Given this list of marker genes FBXO28, CTRC, TIMP1, GCLM, SYT17, MORF4L2 (NCBI Gene Id 9643), MAD1L1, ADRB2, RC3H2, RNF208, H2BC4, H2BC9, SPTBN1, ITGB6, TTC4 (NCBI Gene Id 7268), ADNP2, ZNF646, SOCS3, STAU1, GPC1, PELI1, B3GNT3, ATP2B1, GOLGA7, PDE4DIP, PCK1, ODF2, CAMSAP2, ALG13, TAF4, CA1, EIF6, EPHB6, BEX1, DENND1C, CAPN2, NFE2L2, ITPRID2, MUC5AC, HSPA13, TENT5A (terminal nucleotidyltransferase 5A), CEP70, HGS, SLC12A8, PTP4A1 (protein tyrosine phosphatase 4A1), SCARB2, MEX3C (mex-3 RNA binding family member C), IGBP1, TNFSF14, TMEM41B, HS3ST3A1, TENT4A, PPIF, PCGF3, LRRC8B, GAK, MYH7B (myosin heavy chain 7B), SCG2, CYTH4 (NCBI Gene Id 29776), CHSY1, PORCN, MAMLD1, MTSS2 (NCBI Gene Id 92154), SGMS1, PMAIP1, CNTRL, BACH2, S100P, AGAP2, GPR52, GVINP1, TSPYL1, HMGCS1, NRDC, SAMD9, ZBTB43, ZYX, ACYP1, PHF2, FASTKD5, SCG5, ERCC1, SRSF5, ENDOD1, ACSL3, GSPT2, SLC19A1 (NCBI Gene Id 6573), MOAP1, UBE2H, RGS1, CEBPB, AFF4, SFPQ, CNIH4, DOCK10, ECD, ELK4, NUP88, SFMBT1, LPXN, SMAD3, USP6NL, NR3C1 (nuclear receptor subfamily 3 group C member 1), CHGA, CHRD, MEF2D, GRM1, ANXA1, RNF19B, BCL2A1, CMKLR1, GLS, TMEM39A, ZNF426, ODR4, EIF4E, PRNP, ARHGEF7, PROC, SQLE, FFAR3, SUPT6H (SPT6 homolog, histone chaperone and transcription elongation factor), UBAP1, EFHD2, CMC2, HSPA9, RNF10, ANXA10, ATXN3, TM4SF1, DAPK2, C11orf24, DR1, ACTL8, ATF1, UBE3A, JMJD6, OSGIN1, LIPG, KCNC4, ZNF274, FAM83E, CALCOCO1, MMP2, NR4A1, DCP1A, CASP7, PSEN1, LEMD3, RHBDF2, ME1, ATF5, BCL10, AMMECR1, KPNA2, TNF, KRT8P12, ASH1L, MACO1, EPHB4, CLIP2, YES1, HGSNAT, ARF6, TGM1, DNAJB12, MDM4, UBA6, CBX4, NUP58, MADCAM1, PI4K2A (phosphatidylinositol 4-kinase type 2 alpha), CDV3, COPB1, GHITM, ROBO4, IL1R2, NCAPG (NCBI Gene Id 64151), RTL10, GALNT6, WDR37, S100A11, G3BP2, AGO2, MSC, CCDC59, PFKFB3, DNAH17, CHRNA10, HOXB9, PSMC3IP, PLK2, NSMF, RXRA, CDC37, MSX1, CTTN, TP53BP2, here is a description of the gene set: from publication Kang SG, Park J, Cho JY, Ulrich B, Kim CH (PMID 20664575) Human Gene Set: GSE20500_RETINOIC_ACID_VS_RARA_ANTAGONIST_TREATED_CD4_TCELL_DN Genes down-regulated in CD4 T cells: tretinoin versus Ro 41-5253. studied in species Homo sapiens This is to determine the T cell genes regulated by retinoic acid.